Given this list of marker genes H2-Ea, Cd74 (NCBI Gene Id 16149), Nod2, Fgl2 (fibrinogen-like protein 2), Ccl21a, Clec4a2, Nod1, Thbs1, Slc11a1, Cd68, Ccr7, Clec4a3, Ccl19, Washc1, Clec4a4, Fcgr4, Mpeg1, here is a description of the gene set: Mouse Gene Set: GOBP_DENDRITIC_CELL_ANTIGEN_PROCESSING_AND_PRESENTATION species: Mus musculus The process in which a dendritic cell expresses antigen (peptide or lipid) on its cell surface in association with an MHC protein complex.